Given this list of marker genes NR1D1 (NCBI Gene Id 9572), MED23, AGT, SREBF1, CDK19, MED9, TXNRD1, ABCB4, MED12, MED26, MED15, MED31, NCOA2, NCOA3, RORA, MED17, TNFRSF21, CCNC, ACADM, NFYC, UGT1A9, MED30, CREBBP, PPARA, MED1, CYP7A1, MED4, CYP4A11, CPT1A, TBL1X, MED10, MED18, APOA1, BMAL1, EP300, ANGPTL4, MED6, MED28, NPAS2, ACOX1, NRF1, PPARGC1A, HMGCR, AHR, MED13, GPS2, MED19, MED16, GLIPR1, HDAC3, ABCA1, ARNT2 (aryl hydrocarbon receptor nuclear translocator 2), PEX11A, ANKRD1 (NCBI Gene Id 27063), FABP1, CDK8, HMGCS1, MED11, MED22, NR1H4, MED27 (mediator complex subunit 27), MED20, MED24, PLIN2, NCOA6, SIN3A, FADS1, ESRRA, FHL2, NR1H2, CLOCK, PPARG, FAM120B, MED13L, MED29, ACSL1, ALAS1, TRIB3, CYP1A1, SREBF2, SP1, APOA5, CD36, HMGCS2, MED25, CARM1, GRHL1, MTF1, NFYB, CHD9, CPT2, TGS1, THRAP3, NFYA, APOA2, AHRR, RXRA, G0S2, RXRB, PPARGC1B, HELZ2, RGL1, MED7, SLC27A1, SMARCD3, SIN3B (SIN3 transcription regulator family member B), NCOA1, SULT2A1, MED14, TIAM2, NCOR1, ME1, FDFT1, MED8, ARNT, MED21, TBL1XR1, NCOR2, NR1H3, here is a description of the gene set: part of: Metabolism of lipids Reactome Pathway: Regulation of lipid metabolism by PPARalpha studied in species Homo sapiens Peroxisome proliferator-activated receptor alpha (PPAR-alpha) is the major regulator of fatty acid oxidation in the liver. PPARalpha is also the target of fibrate drugs used to treat abnormal plasma lipid levels. <br>PPAR-alpha is a type II nuclear receptor (its subcellular location does not depend on ligand binding). PPAR-alpha forms heterodimers with Retinoid X receptor alpha (RXR-alpha), another type II nuclear receptor. PPAR-alpha is activated by binding fatty acid ligands, especially polyunsaturated fatty acids having 18-22 carbon groups and 2-6 double bonds. <br>The PPAR-alpha:RXR-alpha heterodimer binds peroxisome proliferator receptor elements (PPREs) in and around target genes. Binding of fatty acids and synthetic ligands causes a conformational change in PPAR-alpha such that it releases the corepressors and binds coactivators (CBP-SRC-HAT complex, ASC complex, and TRAP-Mediator complex) which initiate transcription of the target genes.<br>Target genes of PPAR-alpha participate in fatty acid transport, fatty acid oxidation, triglyceride clearance, lipoprotein production, and cholesterol homeostasis.